The following is a description of a gene set: studied in species Homo sapiens Acrosome Reaction and Sperm:Oocyte Membrane Binding Human Gene Set: REACTOME_ACROSOME_REACTION_AND_SPERM_OOCYTE_MEMBRANE_BINDING, and this is the list of marker genes: CD9, IZUMO1 (izumo sperm-oocyte fusion 1), IZUMO4, IZUMO2, IZUMO3, ACR